The following is a description of a gene set: species: Mus musculus Genes predicted to be targets of miRBase v22 microRNA mmu_miR_686 in miRDB v6.0 with MirTarget v4 prediction scores > 80 (high confidence targets). Mouse Gene Set: MIR_686 from publication Chen Y, Wang X (PMID 31504780), and this is the list of marker genes: Dnm3, Tle4, Gpcpd1, Ssh2, Map1b, Gcc2, Tbx2, Cdkn1b, Krcc1, Bmpr2, Arhgef10l, Ash1l, Dlc1, Ing3, Sbno1, Akr1e1, Negr1, Sptlc3, Gabpb1, Cdh12, Snx2 (NCBI Gene Id 67804), Scai, Prkaa2, Aebp2, Etv1, Mcl1, Col4a5, Rragd, Prrc2b, Tnrc6b, Tmed8, Mecp2, Kcnb1, Bltp3a, Cpne3, Fthl17b, Abhd17a, Bmt2, Zdhhc20, Kdm7a, Suv39h2, Mtarc1, Fbxw2, Ralgapb, Golph3l, Brs3, Bmi1, Zmynd8, Tmcc1, Fubp1, Kif3b, Zfp329, Lrrc8a, Ccdc121rt1, Cacnb3, Jchain, Alkal1, Oxr1, Lrp4, Hdac2, Fthl17c, Csmd1, Lrrtm2, Mab21l2, Creb5, Brd10, Ablim1, Fgf9, Agap1, Cdc73 (NCBI Gene Id 96910, cell division cycle 73, Paf1/RNA polymerase II complex component), Plce1, Paqr6, Ep300, Macrod2, Paqr9, Eif3e, Bhmt, Wsb1, Vti1a, Hsd3b1, Zfp942, Zfp385b, Heca, Erbin, Pomt1, Sp140l2, Etf1, Cdh11, Arpp21 (NCBI Gene Id 94243), Abcd2, Cacna2d1, Pcmtd1, Fam110c, Slc8a1, Bag4, Dennd5b, Dcbld2, Bicral, Glb1l2, Snap23, Nfasc, Fthl17f, Dcun1d2, Rspo3, Lin7a, Pakap, Slc43a2, Stk39, Cfap299, Uso1, Srsf2, Cpne8, Atf7ip, Tnpo1, Cpxm2, Nxf2, Ppp4r2, Vma21, Abracl (NCBI Gene Id 73112), Hnrnpdl, Smco1, Lnx2, Zmat3, Lmtk2, Mospd1, Canx, Bbx, Vstm2a, Tfdp2, Plxnc1, Itk, Lims1, Zfp366, Sec22c, Ahcyl1, C1qtnf7, Lrrc39, Mak, Copg2, Erbb4, Enc1, Fthl17e, Tsc22d2, Plxdc2, Il5, Mtss1, Macc1, Fbxl17, Wdr7, Akap10, Numb, Dolk, Srpx, Lysmd4, Phyhipl, Abi1, Cbln2, Mroh2a, Ccr3, Sec23ip, Vat1l, Epb41l3, Tfb2m, Hoxa5, Iqcb1, Gabrb2, Acvr1, Sema3a, Lamp1, Otx2 (orthodenticle homeobox 2), Npb, Ppy, Fthl17d, Raver2, Galnt6 (polypeptide N-acetylgalactosaminyltransferase 6), Gpm6b, Cdh6, Nup153